The following is a description of a gene set: Mouse Gene Set: GOBP_EMBRYONIC_CLEAVAGE species: Mus musculus The first few specialized divisions of an activated animal egg., and this is the list of marker genes: Nr5a2, Top2a, Aatf, Cul3, Top1, Ercc2, Dppa3, Padi6, Pik3cb (NCBI Gene Id 74769), Tpra1